The following is a description of a gene set: Mouse Gene Set: GOMF_OXIDOREDUCTASE_ACTIVITY_ACTING_ON_THE_CH_CH_GROUP_OF_DONORS_WITH_A_FLAVIN_AS_ACCEPTOR Catalysis of an oxidation-reduction (redox) reaction in which a CH-CH group acts as a hydrogen or electron donor and reduces a flavin. species: Mus musculus, and this is the list of marker genes: Acadvl, Acad9, Ivd, Acad12, Acadl, Acadm, Acad11, Acad8, Acadsb, Acad10, Acads, Gcdh (NCBI Gene Id 97486)